Given this list of marker genes Hdac10, Sat2, Paox, Hdac6, Sat1, Amd2, Dhps, Srm, Amd1, Satl1, here is a description of the gene set: Mouse Gene Set: GOBP_SPERMIDINE_METABOLIC_PROCESS The chemical reactions and pathways involving spermidine, N-(3-aminopropyl)-1,4-diaminobutane. studied in species Mus musculus